Given this list of marker genes Arhgef7, Cdc42, Egfr, Areg, Rps27a, Btc, Ptpn3, Spry2, Ptprk, Stam, Tgfa, Epgn, Ubb, Spry1, Cbl, Eps15l1, Sh3gl3, Epn1, Ptpn12, Grb2, here is a description of the gene set: part of: Signaling by EGFR studied in species Mus musculus electronically inferred by orthology from the curated human pathway Reactome Pathway: EGFR downregulation This event has been computationally inferred from an event that has been demonstrated in another species.<p>The inference is based on the homology mapping from PANTHER. Briefly, reactions for which all involved PhysicalEntities (in input, output and catalyst) have a mapped orthologue/paralogue (for complexes at least 75% of components must have a mapping) are inferred to the other species.